Given this list of marker genes BDH2, ALKBH2, GSTM2, VPS37A, SH3YL1, ARMCX5, MAIP1, TTC3, COX18, FBXO24, ABCG8, RPL22, CCL4, AGER, YTHDF1, KLRK1, RBM42, ZFTRAF1, GTF2A2, ESF1, MED21, ERCC6L2, CNIH4, DNTTIP2, BRD10, STMP1, OXGR1, THEM4, AREG, CCDC171, MIR501 (NCBI Gene Id 574503), IL7R, RSF1, MOS, MMP16, AHSG, STBD1, NEK11, KRT6B (keratin 6B), OSGEP, SPR, GPR65, NHLRC4, B4GALT7, HOXB4, LRRC23, MBLAC2, CCL25, KLRD1, IRF2BP1, GPX8, DEXI, RMI1, BLOC1S4, PRUNE2, FOXC2, LRIF1, EIF1 (eukaryotic translation initiation factor 1), LRRC75A, THOC2, HOPX, AVPI1, DBNDD2, LRRCC1, RADX, PARP8, NOL8, TEAD3, RPL30, CHD3, POLRMT, TNNI3, C10orf120, SMNDC1, MLF1, GPX5, TMEM65, MPLKIP, SOCS6, SLC7A6OS, KLF2, ZFP1, C12orf71, SDSL, OSGEPL1, NFKBIA (NCBI Gene Id 4792), PHF21B, ZFP69 (ZFP69 zinc finger protein), STOML3 (stomatin like 3), SCLT1, TSHB, MEIS1, HLA-B, DBF4, POLR1F, NPFF, ZBBX, INSL6, EVX2, EPC2, DPYSL4, CCDC115, WDR49, LRRC4C, OFD1, TRIM28, TAS1R3, PGRMC2, ABRAXAS1, SAMD3, VKORC1, TXLNG, PTTG1, KCNIP3, ALDH4A1, GCNT4 (glucosaminyl (N-acetyl) transferase 4), TRHR, MAPKAPK5, PIGP, MYH14, TMEM9B, AGPAT5, IRAG1, PHC3, PANTR1, GRM8, CALHM6 (NCBI Gene Id 441168), FAIM, C1orf21, TTC14, FSTL1, UNC80, GLDC, FASTKD3, GAB3, MARCHF5, GDF9, CARD6, FIBP (FGF1 intracellular binding protein), FSHB, SWT1, CILP, CCDC102A, SYT15, PGF, PURB, PFN2 (profilin 2), MAFK, DCLK3, ALLC, here is a description of the gene set: from publication Arenzana TL, Smith-Raska MR, Reizis B (PMID 19329779) Human Gene Set: GSE13547_CTRL_VS_ANTI_IGM_STIM_ZFX_KO_BCELL_12H_UP species: Homo sapiens The development, homeostasis and function of B lymphocytes involve multiple rounds of B cell receptor (BCR)-controlled proliferation and prolonged maintenance. We analyzed the role of transcription factor Zfx, a recently identified regulator of stem cell maintenance, in B cell development and homeostasis. Conditional Zfx deletion in the bone marrow blocked B cell development at the pre-BCR selection checkpoint. Zfx deficiency in peripheral B cells caused impaired generation of the B-1 cell lineage, accelerated B cell turnover, depletion of mature recirculating cells, and delayed T-dependent antibody responses. Zfx-deficient B cells showed normal proximal BCR signaling, but impaired BCR-induced proliferation and survival. This was accompanied by aberrantly enhanced and prolonged integrated stress response, and delayed induction of Cyclin D2 and Bcl-xL proteins. Thus, Zfx restrains the stress response and couples antigen receptor signaling to B cell expansion and maintenance during development and peripheral homeostasis. Genes up-regulated in B lymphocytes: ZFX knockout versus wildtype cells stimulated by anti-IgM for 12h.